The following is a description of a gene set: The synthesis of ribosomal RNA (rRNA), any RNA that forms part of the ribosomal structure, from a DNA template. Mouse Gene Set: GOBP_RRNA_TRANSCRIPTION species: Mus musculus, and this is the list of marker genes: Dedd, Ubtf, Polr1d, Mtor, Polr1b, Ang2, Ddx11, Taf1b, Polr1e (polymerase (RNA) I polypeptide E), Ang4, Ercc6, Pih1d1, Nol11, Ippk, Macroh2a1, Polr1g, Polr2e, Ang6, Pwp1, Smarcb1 (SWI/SNF related, matrix associated, actin dependent regulator of chromatin, subfamily b, member 1), Nop53, Npm3, Spin1, Polr1f, Ercc3 (excision repair cross-complementing rodent repair deficiency, complementation group 3), Macroh2a2, Ang, Smarca4, Polr1a, Npm1, Top1, Ercc2, Sirt7, Ncl, Trp53, Gtf2h5, Mars1 (NCBI Gene Id 23941), Tcof1, Gtf3c1, Cdkn2a, Ang5, Cavin1